The following is a description of a gene set: from publication Cao J, O'Day DR, Pliner HA, Kingsley PD, Deng M, Daza RM, Zager MA, Aldinger KA, Blecher-Gonen R, Zhang F, Spielmann M, Palis J, Doherty D, Steemers FJ, Glass IA, Trapnell C, Shendure J (PMID 33184181) Marker genes curated from the annotated cluster as represented in the Descartes Human Gene Expression During Development database. The gene expression program underlying the specification of human cell types is of fundamental interest. The study authors generated human cell atlases of gene expression and chromatin accessibility in fetal tissues. For gene expression, the study authors applied three-level combinatorial indexing to >110 samples representing 15 organs, ultimately profiling ~4 million single cells. The study authors leveraged the literature and other atlases to identify and annotate hundreds of cell types and subtypes, both within and across tissues. Our analyses focused on organ-specific specializations of broadly distributed cell types (such as blood, endothelial, and epithelial), sites of fetal erythropoiesis (which notably included the adrenal gland), and integration with mouse developmental atlases (such as conserved specification of blood cells). These data represent a rich resource for the exploration of in vivo human gene expression in diverse tissues and cell types. species: Homo sapiens Human Gene Set: DESCARTES_MAIN_FETAL_HORIZONTAL_CELLS, and this is the list of marker genes: CACNG3, NDST3, TANC1, MIR2052HG (NCBI Gene Id 441355), ESRRB, TLE4, ENSG00000203900 (NCBI Gene Id 100133187), FCHSD1, LINC02609, ARHGAP26-IT1, TPM3, EPM2A, MIR181A2HG, SEM1, IL12A-AS1, CACNG7, ERC1, ENSG00000259203, CNTN4, PMFBP1, PLAC8L1, RNU1-33P, TFAP2B, RAB11FIP4, MRPL37P1, LINC02565, ENSG00000249695 (novel transcript, antisense to IQSEC3), RPL17P23, B3GAT2, DRD2, ONECUT3, DCTN1-AS1, HS6ST1, SEMA6A-AS2, MEGF11, ARHGEF4, ONECUT2, LINC01416, LINC02842, PAK5, MALT1, TIGD3, TNR, GRIA3, TNR-IT1, ONECUT1